The following is a description of a gene set: Genes predicted to be targets of miRBase v22 microRNA mmu_miR_3079_5p in miRDB v6.0 with MirTarget v4 prediction scores > 80 (high confidence targets). studied in species Mus musculus Mouse Gene Set: MIR_3079_5P from publication Chen Y, Wang X (PMID 31504780), and this is the list of marker genes: Map7, Kif3c (NCBI Gene Id 16570), Jag1, Spesp1, Zfp438, Irag1, Pea15a, Ptp4a2, Yy2, Atp2b3, Med13l, Gabrb2, Adra2a (NCBI Gene Id 11551), Lyplal1, Adarb2, Mosmo, Mmut, Efnb3, Sirpa, Surf2, Zfp606, C1ql3, Man1a, Tshz1 (teashirt zinc finger family member 1), Mbd5 (NCBI Gene Id 98951), Zfp729a, Erp44, Strbp, Trim21, Rpusd3, Zbtb14, Ncam1, Zmiz1, Ldhb, Rbms2, Arhgap24, Tmem196, Cpn2, Olfml2b, Ppwd1, Prkca, Chd9, Pole3, Prss35, Ykt6, Gpr50, Rasef, Tex2, Suclg2 (NCBI Gene Id 28021), Ppip5k1, 1810010H24Rik, Ktn1, Arl2bp, Lhx4, Kremen1, Sox11, Nufip2, Txndc16, Mapkap1, Hypk, Atg7, Gucy1a2, Pyurf, Ccdc85a, Acsl3, Homer1, Stau1, Myo5b